Given this list of marker genes FGFR3, STIM1, AHDC1, GAP43, DNAJC22, PKD1L1, PRDM2, CABP7, SCNN1A, TBX6, OTP, ADM2 (NCBI Gene Id 79924), IFFO2, ITGA7, CCNT1, FCER1G, BCORL1, CALN1, HIC2, DHCR24, UNC5B, DLC1, IRX2-DT, FRMPD1, DNAJB5, GOLM1, DAGLA, ZNF821, FOXP4, TFE3, FKBP1A, MDFI, SRF, MEOX1, COL5A3, EPHA1, TRIM3, HOXB6, COPS6, IGF2, PLCH1, GRID1, PHF8, CCDC103, VSX2, NECAB3, TSPAN11, DNAJC14, SYNGAP1, SCRT1, RXRG, CORO2B, NPTXR, RANBP3, MNT, GNAO1, PADI1, NCS1, MECP2, JUP, STEAP3, AMIGO1, NTSR1, PPP1R11, P2RY11, CHRNE, ANKRD34A, ARHGDIB, NGFR, TMEM178B, SZRD1, GSG1L, KPNA6, ST6GALNAC6, CACNA1E, TMCC3, FZD8, ZMYND10, PAPPA2, NOS1, ELAVL3, DLK1, WDR26, ZSCAN23, SH3PXD2A (NCBI Gene Id 9644), FXR2, S100A1, SYNPO2L (synaptopodin 2 like), ATXN7L3, FAM78B, VCF1, CMIP, KCNA6, SLC7A1, IL24, FAM219A (family with sequence similarity 219 member A), NDOR1, BAZ1B, SKI, ATP1B2, SH2B1, RAB7A, TTC9, LRRC20, FURIN, ZNF609, SMARCD1, MEF2D, PHOX2A, DENND1C, EFNA5, FCHSD1, AGPAT1, GLIS2, FBXL18, GJB1, HBEGF, TMEM104, ARFIP2, GIT1, RUNDC3A, TIAM1, FLT4, NOVA2 (NOVA alternative splicing regulator 2), ARRB1, MAPK6, TTYH3, DNAJC5G, VAMP1, FZD7, IRF2BP1, PBX2, SEPTIN9, SORBS3, NRN1, STK32C, QKI, NAA15, PRELP, ENTPD1, POPDC2, CNTN2, TMEM63B, ATP2B2, NR5A1, RIMS4, IL12RB1, BCAM, CCDC97 (coiled-coil domain containing 97), ZKSCAN8, KIF3A, AATK, ATAD3C, ARL3, WNK4, SLC6A11, TRIM35, MKNK2, POU2F2, RHOF, RAB36, TESPA1, TNS4, INTS3, H2BC21, B3GNT3, HSPG2, PPAN-P2RY11, PAX5, S100A11, MGAT5B, DIRAS1, SLC43A2, RNF126, SCN2B, ZMYM1, LIF, AP1M1, SOD3 (NCBI Gene Id 6649), SEMA3G, ARF3, OLFM2, PPP1R9B, KIF21B, ENTPD2 (ectonucleoside triphosphate diphosphohydrolase 2), RABL2A, NFIX, TOR4A, NFIC, KIRREL1, BSN, CASR, HIVEP3 (HIVEP zinc finger 3), HHLA2, CELF5, PLAGL2, WDTC1, FBXO41, ISG20, POU2F1, MAPK3, DCBLD1, MPV17L, IQCK, SDR42E1, CD48, ZBTB9, RABL2B, PCDHGA12, GNG7, REEP2, MGRN1, CDC42BPA, REXO1, ZBTB7A, CST4, CES4A, SSBP3, MEX3A, PRKACA, PHF21A, TMEM242, FAM193A, BAHCC1, BHLHE40, IQSEC3, RNASE13, PHF12, CYP2W1, NKD1, IQSEC2, SMURF1, KCNK9, FASN, CEP170B, C16orf46, HYOU1, CLCF1, SPATA33, KCNAB2, MDGA1, TPRN, PDE4C, HPCA, MTSS2, SRRM4, PHF23, TNRC18, SLC24A2, KMT2D (lysine methyltransferase 2D), CACNA2D2, EPHA8, CHKB (NCBI Gene Id 1120), ECM1, ANKRD13B, here is a description of the gene set: Human Gene Set: MIR6756_5P Genes predicted to be targets of miRBase v22 microRNA hsa-miR-6756-5p in miRDB v6.0 with MirTarget v4 prediction scores > 80 (high confidence targets). species: Homo sapiens from publication Chen Y, Wang X (PMID 31504780)